Given this list of marker genes Mif, Stap1, Mmp28, Slamf8, Cyp19a1, Hc, here is a description of the gene set: studied in species Mus musculus Any process that decreases the rate, frequency or extent of macrophage chemotaxis. Macrophage chemotaxis is the movement of a macrophage in response to an external stimulus. Mouse Gene Set: GOBP_NEGATIVE_REGULATION_OF_MACROPHAGE_CHEMOTAXIS